Given this list of marker genes TUBB4A, PSMD11, PRKAR2B, PSMA6, ADCY7, TUBB4B, PSMC5, TUBA4A, ADCY6, PSMA2, IFT172, TULP3, WDR35, SUFU, PRKAR1B, PSMB4, PSMA1, KIF7, WDR19, PRKACG, GNAS, GSK3B, PSMB2, TUBA1B, ADRM1, OFD1, TUBB2A, CUL1, UBC, PRKACB, ADCY3, PSMA5, IFT122, CSNK1A1, TUBA3D, PSMD7, PSMD6, PSMD2, IFT140, BTRC, PSMD3, NUMB (NUMB endocytic adaptor protein), ADCY5, IFT52, PSMD12, PRKAR1A, TUBA1C, PSMC1, PRKACA, SKP1, ADCY4, PSMB1, PSMC6, PTCH1, PSMD8, PSMD13, PSMC2, PSMB5, SMO, PSMB3, TTC21B, UBB, ADCY2, TUBA3C, KIF3A, GPR161, PSMC4, IFT57, PSMA3, GLI3, GLI2, UBA52, GLI1, ADCY10, MKS1, ADCY1, PSMB7, RPS27A, DYNC2H1, INTU, IFT88, PSMD14, TUBB3, TUBB1, ITCH, PSMC3, PSMA7, TUBB2B, ADCY9, PSMB6, PSMD1, SEM1, TUBB6 (tubulin beta 6 class V), ADCY8, RBX1, PRKAR2A, TUBA1A, FUZ, PSMA4, RPGRIP1L, here is a description of the gene set: Hedgehog 'off' state Human Gene Set: REACTOME_HEDGEHOG_OFF_STATE species: Homo sapiens